Given this list of marker genes Ptger4, Ccn4, Hras (Harvey rat sarcoma virus oncogene, NCBI Gene Id 15461), Ptk2, Prkce, Hmgb1, Kank1, Cntf, Cxcr4, Ntrk3, Fermt1, Plau, Atp7a, Vwf, Braf, Stk24, Ccl2, S100a9, St3gal4, Adra2a, Cldn1 (NCBI Gene Id 12737), Fermt2, Thbs1, Insl3, Prdx2, Actg1, F2, Emilin2, Ddr2, Vtn, Smoc2, F2r, Hpse, Scarf1, Cldn13, Tmem97, Foxc2, Hrg (histidine-rich glycoprotein), Cd24a (CD24a antigen), Cldn4, Apoh, Cpb2, Grn, Reg3g, Nfe2l2, Serpinf2, Emilin1, Vegfb (NCBI Gene Id 22340), Ptn, Cldn3, Rreb1, Xbp1, Igf1r, Cd36, Lrp1, Mtor, Serpine1, Ndel1, Ano6, Duox1, Pum2, Fkbp1b, Mylk, Duox2, Tbxa2r, Mdk, Dmtn, Enpp4, Hif1a, Itgb1, Hbegf, Anxa1 (NCBI Gene Id 319730), Nrg1, Plg, Arfgef1, Plat, Reg3a, Clec7a, Flna, F12, F7, here is a description of the gene set: Any process that activates or increases the frequency, rate or extent of response to wounding. species: Mus musculus Mouse Gene Set: GOBP_POSITIVE_REGULATION_OF_RESPONSE_TO_WOUNDING